The following is a description of a gene set: An abnormal concentration of a hormone in the urine. studied in species Homo sapiens Human Gene Set: HP_ABNORMAL_URINE_HORMONE_LEVEL Abnormal urine hormone level, and this is the list of marker genes: CDKN2A, CDKN1B, ATRX, CYP17A1, TP53, ARMC5, TERT, USP48, KDM1A, CDH23, BRAF (NCBI Gene Id 673), NR3C1, HSD11B1, ZNRF3, PRKAR1A, CTNNB1, CYP11B1, USP8, GNAS